The following is a description of a gene set: Human Gene Set: HP_ABNORMAL_CIRCULATING_ASPARTATE_FAMILY_AMINO_ACID_CONCENTRATION Any deviation from the normal concentration of an aspartate family amino acid in the blood circulation. Abnormal circulating aspartate family amino acid concentration studied in species Homo sapiens, and this is the list of marker genes: MMADHC, AHCY, ADK, ABCD4, MAT1A, AASS, SLC25A13, NADK2, FAH, MTRR, MICU1, MMACHC (metabolism of cobalamin associated C), ASNS, PNPO, TFAM, GUCY2D, SLC7A7, CBS, SKIC3, GNMT (glycine N-methyltransferase), LMBRD1, PRDX1, MTHFR, MTR